Given this list of marker genes AIG1, PEX2, PLIN5, ABHD2, PHYH, PCCB, CPT1B, PPARD, NUDT8, ACAT1, BDH2, ALDH1L2, DECR1, CPT1A, ABCD1, PCK1, ECH1 (enoyl-CoA hydratase 1), ABCD2, ABCD3, AUH, MLYCD, ETFA, ETFBKMT, PEX13, AKT2, ECI1, GLYATL2, ECHS1, ADTRP, MCAT, SLC27A4, ACBD5, ACOX3, ECI2, MTLN, NUDT19, FAAH, TYSND1, ABHD3, PEX7, ADIPOQ, LPIN3, ACOT8, LPIN1, PCCA, ACAD10, ACADS, EHHADH, ACADVL (acyl-CoA dehydrogenase very long chain), ABCB11, ILVBL, ABHD1, LPIN2, CROT, CYP4A11, IVD, ACOT7, IRS1, HSD17B4, HACL1, CYP4F2, CRAT, ETFDH, AKT1, ACAD11, CYP4F12, SLC27A2, ECHDC1, GCDH, ACOX2, CYP4F3, AMACR, HAO1, ACAA1, LEP, ACADL, ACADM, HADHA, NUDT7, MCEE, ACAA2, ACACB, PLA2G15, CPT2, PEX5, HADH, SESN2, ACOXL, HADHB, TWIST1, DECR2, ACOX1, ETFB, ENSG00000293349, MFSD2A, ECHDC2, IRS2, HSD17B10, SLC25A17, ABCD4, LONP2, PPARA, SCP2, PCK2, here is a description of the gene set: The chemical reactions and pathways resulting in the breakdown of a fatty acid, any of the aliphatic monocarboxylic acids that can be liberated by hydrolysis from naturally occurring fats and oils. Fatty acids are predominantly straight-chain acids of 4 to 24 carbon atoms, which may be saturated or unsaturated; branched fatty acids and hydroxy fatty acids also occur, and very long chain acids of over 30 carbons are found in waxes. species: Homo sapiens Human Gene Set: GOBP_FATTY_ACID_CATABOLIC_PROCESS